The following is a description of a gene set: The process whose specific outcome is the progression of the cranial nerves over time, from its formation to the mature structure. The cranial nerves are composed of twelve pairs of nerves that emanate from the nervous tissue of the hindbrain. These nerves are sensory, motor, or mixed in nature, and provide the motor and general sensory innervation of the head, neck and viscera. They mediate vision, hearing, olfaction and taste and carry the parasympathetic innervation of the autonomic ganglia that control visceral functions. studied in species Homo sapiens Human Gene Set: GOBP_CRANIAL_NERVE_DEVELOPMENT, and this is the list of marker genes: EXT1, PHOX2A, KCNA2, ADARB1, HOXD3, NAV2, SLC24A4, EPHB1, CHRNB2, DCANP1, ATP8B1, DRGX, HOXB3, CHD7, SEMA3A, RPL24, CTNNB1, HOXA1 (NCBI Gene Id 3198), KCNC2, ATOH7, MAFB, NRP1, EGR2, SEMA3F, TFAP2A, SLC1A3, SIX1, HOXA3, GLI3, PLXNA3, NPR2 (natriuretic peptide receptor 2), HOXB1, EPHB2, HES1, POU4F1, NEUROG1, NDP, CITED2, TCIRG1, TMEM126A, POU4F3, SIX4, SALL1, CNGB1, KCNC1, SLITRK6, NRP2, PLXNA1, ISL1, PAX2, SLC38A8, LPAR1, TIFAB, PLXNA4, SLC25A46, NKX2-2 (NK2 homeobox 2), PHOX2B, ACKR3, TBX1, HOXB2, NTRK1, ERBB3